Given this list of marker genes HOXB6, PLCH1 (phospholipase C eta 1), RAB7A, FGFR3, SCRT1, TNRC18, CMIP (NCBI Gene Id 80790), EPHA8, S100A1, POU2F2, COPS6, MNT, TBX6, MEOX1, TSPAN11, OTP, SCN2B, TMCC3, PADI1, TMEM178B, KIF3A (kinesin family member 3A), REXO1, SSBP3, FZD8 (frizzled class receptor 8), SRRM4, IGF2, SLC43A2, DENND1C, AMIGO1, TMEM104, PDE4C, WDTC1, PHF21A, FKBP1A, NKD1, MGAT5B, ZMYND10, LAMTOR1, CHRNE, ANKRD34A, NR5A1, RHOF, ZSCAN23, ANKRD13B, FBXO41, DNAJC22, OLFM2, KMT2D (lysine methyltransferase 2D), FURIN, AP1M1, SORBS3, SCNN1A, BARHL1, ARRB1, STK32C, RABL2A, IRF2BP1, ATP1B2, ADM2, PRKACA, RNASE13, ATXN7L3 (ataxin 7 like 3), TRIM3, CCDC103, GLIS2, ARHGDIB, HHLA2, HSPG2, SMARCD1, GAP43, PLAGL2, CD48, FAM219A, ATP2B2, TFE3, CACNA1E, DCBLD1, PHF23, MEX3A, CCNT1, ENTPD1, CST4, SH3PXD2A (SH3 and PX domains 2A), IRX2-DT, ZNF609, BAZ1B (NCBI Gene Id 9031), ARF3, IQSEC2, FAM193A, CCDC97, TPRN, SPATA33 (NCBI Gene Id 124045), NECAB3 (NCBI Gene Id 63941), PBX2, CNTN2, NTSR1, ZMYM1, IFFO2, SRF, SZRD1, DNAJC5G (DnaJ heat shock protein family (Hsp40) member C5 gamma), MPV17L (MPV17 mitochondrial inner membrane protein like), VCF1, STIM1, POPDC2, PKD1L1, PRDM2, SH2B1, CELF5, SLC24A2, IL12RB1, RXRG, GNG7, ELAVL3, AHDC1, ARFIP2, MDGA1, KIRREL1, TTYH3 (NCBI Gene Id 80727), ITGA7, FCER1G, TMEM63B, MDFI, HIC2, FLT4, LIF, IL24, RAB36, GOLM1, DHCR24, SMURF1 (NCBI Gene Id 730332), AGPAT1, CHKB, PRELP, TRIM35, H2BC21, SDR42E1, NDOR1, RANBP3, ATAD3C, DNAJC14, QKI, FASN, GNAO1, STEAP3, BHLHE40 (basic helix-loop-helix family member e40), ZNF821, ZBTB7A, RIMS4, GJB1, KIF21B, CDC42BPA, POU2F1, RUNDC3A, KCNAB2, HIVEP3, ISG20, MKNK2, COL5A3, CEP170B, DLC1, MTSS2, PPP1R9B, EFNA5, B3GNT3, NFIX, C16orf46, DNAJB5, KCNK9, CLCF1, DIRAS1, REEP2, WDR26, PHOX2A, PPP1R11, GSG1L, NOS1 (nitric oxide synthase 1), IQSEC3, KCNA6, MECP2, RABL2B, CYP2W1, ZBTB9, TTC9, FRMPD1, VSX2, CES4A, WNK4, CALN1, PCDHGA12, EPHA1, DELE1, FXR2, MEF2D, SLC7A1, ECM1, ZKSCAN8, P2RY11, CORO2B, HBEGF, TESPA1, ARL3, DLK1, PHF12, PAX5, SEMA3G, VAMP1, IQCK, TIAM1, SLC6A11, CACNA2D2, HYOU1, PPAN-P2RY11, HPCA (hippocalcin), NCS1, NPTXR, SKI, MAPK6 (NCBI Gene Id 5597), BAHCC1, PAPPA2, TNS4, GIT1, INTS3, RNF126, NOVA2, SYNGAP1, AATK, SEPTIN9, NFIC, SOD3, FCHSD1, NRN1, JUP, ENTPD2, CASR, TMEM242, MAPK3, here is a description of the gene set: studied in species Homo sapiens Genes predicted to be targets of miRBase v22 microRNA hsa-miR-6766-5p in miRDB v6.0 with MirTarget v4 prediction scores > 80 (high confidence targets). Human Gene Set: MIR6766_5P from publication Chen Y, Wang X (PMID 31504780)